The following is a description of a gene set: Down-regulated genes in B-CLL (B-cell chronic leukemia) patients expressing high levels of ZAP70 and CD38, which are associated with poor survival. from publication Hüttmann A, Klein-Hitpass L, Thomale J, Deenen R, Carpinteiro A, Nückel H, Ebeling P, Führer A, Edelmann J, Sellmann L, Dührsen U, Dürig J (PMID 16932341) B-cell chronic lymphocytic leukaemia (B-CLL) is a heterogenous disease with a highly variable clinical course and analysis of zeta-associated protein 70 (ZAP-70) and CD38 expression on B-CLL cells allowed for identification of patients with good (ZAP-70-CD38-) and poor (ZAP-70+CD38+) prognosis. DNA microarray technology was employed to compare eight ZAP-70+CD38+ with eight ZAP-70-CD38- B-CLL cases. The expression of genes differed significantly between the two subgroups, including genes involved in B-cell receptor signaling, angiogenesis and lymphomagenesis. Three of these genes, that is, immune receptor translocation-associated protein 4 (IRTA4)/Fc receptor homologue 2 (FcRH2), angiopoietin 2 (ANGPT2) and Pim2 were selected for further validating studies in a cohort of 94 B-CLL patients. IRTA4/FcRH2 expression as detected by flow cytometry was significantly lower in the poor prognosis subgroup as compared to ZAP-70-CD38- B-CLL cells. In healthy individuals, IRTA4/FcRH2 protein expression was associated with a CD19+CD27+ memory cell phenotype. ANGPT2 plasma concentrations were twofold higher in the poor prognosis subgroup (P<0.05). Pim2 was significantly overexpressed in poor prognosis cases and Binet stage C. Disease progression may be related to proangiogenic processes and strong Pim2 expression. Human Gene Set: HUTTMANN_B_CLL_POOR_SURVIVAL_DN species: Homo sapiens, and this is the list of marker genes: EGR3 (early growth response 3), CASP1, MEF2C, UTS2, MYBL1, AKT3, TPD52, FCRL2, ZNF532 (NCBI Gene Id 55205), DGKG, KLF3-AS1 (KLF3 antisense RNA 1), PDE8A, COBLL1, ADAMDEC1, SOBP, METTL8, ZNF280D, EAF2, ATP1B1, GLIPR1, ZNF652, VNN2, TCAF1, TCF7, NUCB2, SYNJ2, ADARB1, USP6NL, SLC4A7, CNTNAP2, ADK, FUT8, BANK1, EIF4G3, PIP5K1B, ADAM10, SLC4A8 (NCBI Gene Id 9498), ATP10D, RECK, ZBTB20, BIRC3, ADAM29, BACH2, STAG3, MGAT5, ATP2B1, MTSS1 (NCBI Gene Id 9788), TRAC, SMC5, PLAG1, ALCAM, SOCS5, KIZ, RRAS2, PTK2, HELLS, SLAMF1, NRIP1, FRS2